Given this list of marker genes MT-ND1, MT-TH, MT-CO1, SNCB (synuclein beta), SLC25A13 (NCBI Gene Id 10165), ALAD, MT-TW, MT-ND4, MT-ND6, MT-ND5, GBA1, MT-TS2, YY1, MT-TL1, MT-TF, SNCA, MT-CO2, MEN1, MT-CO3, MT-TQ, here is a description of the gene set: Fluctuations in consciousness Human Gene Set: HP_FLUCTUATIONS_IN_CONSCIOUSNESS species: Homo sapiens Changes in one's level of awareness and responsiveness to their environment.